Given this list of marker genes Adam19, Atosa, Tbc1d19, Phip, Azin2, C2cd2, Spata1, Otulinl, Txndc11, Faf1, Lhfpl6, Ndn, Rgcc, Rictor, Satb1, Asb8, Znfx1, Carmil1, Txlng, Atad2b, Arid1a, Socs5, Zfp644, Sorcs1, Srsf12, Mknk2, Trp63, Cbfb, Yaf2, Krtap14, Tspan2, Amph, Desi2, Sestd1, Pex5, Slco5a1, Naa15 (N(alpha)-acetyltransferase 15, NatA auxiliary subunit), Yipf2, Abhd17b, Cap1, Rnf6, Otx2, Kctd9, Kdsr (NCBI Gene Id 70750), Hsp90ab1, Sbno2, Etl4, A830018L16Rik, Sema6d, Pfkfb2, Kcnd1, Rap1b, Ythdc1 (YTH domain containing 1), Sema4f, Ptpn12, Nrip1, Taok1, Mfn1, Tshz1, Aurka, Ski, Zdhhc2, Aida, Bmp2k, Zfp521, Adam23 (NCBI Gene Id 98648), Gprc5a, Bach2, Ube3a, Epha4, Reck, Zfp558, Scn3a, Klf13, Plcb1, Bnc1, Trim24, Gabra6, Msantd4, Smarcd2, Mast4, Nfic, Adam1b, Apbb2, Kctd6, Utrn, Vezf1, Fmr1, Skint10, Tesk2, Gfpt2, Itsn2, Fam168a, Alg11, Hecw1, Actn4, Dab2, Zfp329, Tagln3, Hspa1b, Ptbp1, Dnm3, Fam168b, Cdk19, Gpr158, Sri, Nr4a3, Sel1l, Hey2, Ss18, Robo2, Grb2, Foxd1, Sptbn4, Dennd1b, Ubfd1, Ccdc12, Fbxo33, Phf20, Irf2bp2, Wsb1, Irx2, Acvr1c, Piga, Gatm, D030056L22Rik (NCBI Gene Id 277265), Lrrc57, Nufip1, Eif4e, Rab12, Rai14, Meis1, Grip2, Paip1, Iqck, Atp6v1c1, Tpk1, Atg5, Mon2, here is a description of the gene set: from publication Chen Y, Wang X (PMID 31504780) species: Mus musculus Mouse Gene Set: MIR_6335 Genes predicted to be targets of miRBase v22 microRNA mmu_miR_6335 in miRDB v6.0 with MirTarget v4 prediction scores > 80 (high confidence targets).